The following is a description of a gene set: species: Mus musculus Mouse Gene Set: GOBP_NEGATIVE_REGULATION_OF_OSTEOCLAST_DIFFERENTIATION Any process that stops, prevents, or reduces the frequency, rate or extent of osteoclast differentiation., and this is the list of marker genes: Lrrc17, Tnfrsf11b, Inpp5d, Pik3r1 (phosphoinositide-3-kinase regulatory subunit 1), Gpr137b, Iapp, Clec2d, Tcta, Ifng, Clec2i, Nf1, Lilrb4a, Tjp2, Inpp4b, Lilrb4b, Ctnnb1, Tmem178, Cldn18, Cartpt, Ceacam1, Clec2g, Mafb, Pilrb1, Pira1, Ccl3, Sfrp1, Ubash3b, Il4, Ifnb1, Ltf, Fbxw7, Fbn1, Tnfaip6, Pira12, Fstl3, Gpr137, Pias3 (NCBI Gene Id 54605), Gpr55, Tob2, Erfe